Given this list of marker genes TRBV5-4, TRBV5-5 (T cell receptor beta variable 5-5), TRBV7-4, TRBV6-1, TRBV12-4, TRBV7-3, here is a description of the gene set: studied in species Homo sapiens from publication Qi Q, Cavanagh MM, Le Saux S, NamKoong H, Kim C, Turgano E, Liu Y, Wang C, Mackey S, Swan GE, Dekker CL, Olshen RA, Boyd SD, Weyand CM, Tian L, Goronzy JJ (PMID 27030598) Human Gene Set: QI_NAIVE_T_CELL_ZOSTAVAX_AGE_52_75YO_CD4_T_CELL_VS_NAIVE_CD4_T_CELL_7_TO_9DY_UP Diversity and size of the antigen-specific T cell receptor (TCR) repertoire are two critical determinants for successful control of chronic infection. Varicella zoster virus (VZV) that establishes latency during childhood can escape control mechanisms, in particular with increasing age. We examined the TCR diversity of VZV-reactive CD4 T cells in individuals older than 50 years by studying three identical twin pairs and three unrelated individuals before and after vaccination with live attenuated VZV. Although all individuals had a small number of dominant T cell clones, the breadth of the VZV-specific repertoire differed markedly. A genetic influence was seen for the sharing of individual TCR sequences from antigen-reactive cells but not for repertoire richness or the selection of dominant clones. VZV vaccination favored the expansion of infrequent VZV antigen-reactive TCRs, including those from naive T cells with lesser boosting of dominant T cell clones. Thus, vaccination does not reinforce the in vivo selection that occurred during chronic infection but leads to a diversification of the VZV-reactive T cell repertoire. However, a single-booster immunization seems insufficient to establish new clonal dominance. Our results suggest that repertoire analysis of antigen-specific TCRs can be an important readout to assess whether a vaccination was able to generate memory cells in clonal sizes that are necessary for immune protection. Genes up-regulated in naive T cell CD4-positive T cell vs naive CD4-positive T cell in seniors (52-75) after exposure to Zostavax, time point 7 to 9D. Comment: Table S3. BV and BJ gene segment usage in VZV-reactive CD4 T cells compared to naive and memory CD4 T cells (FDR <= 0.1).